The following is a description of a gene set: species: Homo sapiens Although IRAK-1 was originally thought to be a key mediator of TRAF6 activation in the IL1R/TLR signaling (Dong W et al. 2006), recent studies showed that IRAK-2, but not IRAK-1, led to TRAF6 polyubiquitination (Keating SE et al 2007). IRAK-2 loss-of-function mutants, with mutated TRAF6-binding motifs, could no longer activate NF-kB and could no longer stimulate TRAF-6 ubiquitination (Keating SE et al 2007). Furthermore, the proxyvirus protein A52 - an inhibitor of all IL-1R/TLR pathways to NF-kB activation, was found to interact with both IRAK-2 and TRAF6, but not IRAK-1. Further work showed that A52 inhibits IRAK-2 functions, whereas association with TRAF6 results in A52-induced MAPK activation. The strong inhibition effect of A52 was also observed on the TLR3-NFkB axis and this observation led to the discovery that IRAK-2 is recruited to TLR3 to activate NF-kB (Keating SE et al 2007). Thus, A52 possibly inhibits MyD88-independent TLR3 pathways to NF-kB via targeting IRAK-2 as it does for other IL-1R/TLR pathways, although it remains unclear how IRAK-2 is involved in TLR3 signaling.<p>IRAK-2 was shown to have two TRAF6 binding motifs that are responsible for initiating TRAF6 signaling transduction (Ye H et al 2002). Reactome Pathway: IRAK2 mediated activation of TAK1 complex upon TLR7/8 or 9 stimulation part of: TRAF6 mediated induction of NFkB and MAP kinases upon TLR7/8 or 9 activation, and this is the list of marker genes: MAP3K7, IRAK2, TAB2, RPS27A, UBC, LY96, TICAM1, UBA52, CD14, UBB, TAB1, TICAM2, TRAF6, TLR4, TAB3